The following is a description of a gene set: species: Homo sapiens from publication Johnson EN, Appelbaum ER, Carpenter DC, Cox RF, Disa J, Foley JJ, Ghosh SK, Naselsky DP, Pullen MA, Sarau HM, Scheff SR, Steplewski KM, Zaks-Zilberman M, Aiyar N (PMID 15585845) Human Gene Set: GSE1791_CTRL_VS_NEUROMEDINU_IN_T_CELL_LINE_0.8H_DN Effects of Neuromedin-U on gene expression in mouse D10.G4.1 T-cells natively expressing the GPCR Axor13 Genes down-regulated in D10.G4.1 T cell line (0.8h): control versus treated with NMU., and this is the list of marker genes: MYOF, VCAM1, CLEC5A, UPK1B, KANK4, SPATS2, NAP1L3, TFAP2A, NR2F2, PDLIM2, TMEM51, GHRHR, NCAPG2, BAALC-AS2, BST1, IL1R2, PCSK7, TUBB4B, SMC1B, NOTCH3, KDELR3, CEP97, TEX41, DNAJC18, SEL1L2, VCP, TEX19, FRY, DUSP6, RASAL2, MEX3B, LINC00308, NWD2, CAMK1, CCDC144A, RSPO3, SPINK5, SPTLC3, WDR91, ZNF532, ZNF630, CELF2, CD84, CD200R1, EPOP, GAL3ST4, SLX4IP, ARHGEF9 (NCBI Gene Id 23229), ZNF8 (NCBI Gene Id 7554), NOX4, ARTN, OR5H1, SERPINI1, SCN8A, TMEM121B, DNAJB5, DSG1, ZFPL1, SPATA6, JAM2, TEX36, RUNX3, MEF2A, ATP6V0A1, BRCA2, IER5L, RXRA, MOBP, PKD2L1, TUNAR, ANKZF1, TLL1, BABAM2, TRIM32, KCNJ11, SLAMF8, BHLHE40, PLXDC2, WNT7A, EFNA5, C11orf21, LINC02995, DIAPH1-AS1, LIN54, DOK1, ACO2, CHST11, KLF17P1, GPNMB, CDKN1A, TXNDC8, LINC00857, PTS (NCBI Gene Id 5805), ASAP1, KRT77, C5AR1, PLA2G6, KCNT2, STX1A, ADARB2-AS1, SELE, CD63, PSAPL1, SDHAP2, IFT122, B4GALT6, COL3A1, GSN, SH3TC1, TMEM176A, CEACAM21, PPP1R13B, FRMD4A, ARAP3 (NCBI Gene Id 64411), KITLG, CGN, DNAH6, PTGS1, CNPY1 (NCBI Gene Id 285888), RTL5, ALDH1A3, OFCC1, B3GALT5 (beta-1,3-galactosyltransferase 5), DHRS4-AS1, ATP6V0B, PAK1, ITGAM, CAMK1D, SH3BP5, SPECC1, EXT1, OPN4, MAGEA4, DPY19L2P3 (NCBI Gene Id 442524), P2RX1, CACNB3, ZNF442, ZNF568, POLR1G, SLC26A11, SERTAD4-AS1, HCLS1, FAM89B, ATP9B, EPHX3, UBTF (NCBI Gene Id 7343, upstream binding transcription factor), FBP1, FGL2, PCDH7, CCL24, SLC2A3, BRF2, DPH3P1, CTBP1-AS, CACYBP, ACTN1, GPR65, IHH, TCAF2, IL1RAP, ITPKB, FANCB, ASMTL-AS1, IL18BP, CDC37, C2CD2L, CIART, CCR3, OR2L1P, GPR68, ENSG00000288011, DYDC1, SH3RF3 (SH3 domain containing ring finger 3), ZBED10P, HTT, UBTD1, PTCHD1, SIGIRR, TMEM225, EQTN (equatorin), CYC1 (NCBI Gene Id 1537), IFNE, UGT2B4, PREX2, DTHD1, UBE2M, HACD1, DTWD2, KCNK6, ZNF736, OSTCP1, IL12RB1, NAALAD2, CELF5